Given this list of marker genes AMMECR1, BRCA2, SMARCAL1, WT1, COL4A5, CTNS, TRIP13, NUP85, H19, ACSL4, LMNB2, PBX1, ADAMTS13, LPIN2, SLC37A4, LMX1B, CLDN16, INF2, TRIM28, CUBN, COL4A3, F2, FN1, DIS3L2, KCNE5, CFHR5, POU6F2, REST, PAX2, GPC3, CLCN5, NOS1AP, APOA1, here is a description of the gene set: Microscopic hematuria Human Gene Set: HP_MICROSCOPIC_HEMATURIA Microscopic hematuria detected by dipstick or microscopic examination of the urine. studied in species Homo sapiens